Given this list of marker genes DDX18, MYOD1 (NCBI Gene Id 4654), NRIP1, KAT5, KIF18A, MSX2, RAMP3, SSTR1, FAM210B, ESR2, LCOR, GPER1, SFRP1, ZNF703, CFLAR, H2AZ1, NCOA3, HNRNPD, ITGA2, RUVBL2, CCDC62 (coiled-coil domain containing 62), MYOG, PPP1R9B, SRD5A1, HSF1, CRHBP, ABCB1, POU4F1, MMP2, SSTR2, POU4F2 (POU class 4 homeobox 2), AIFM1 (apoptosis inducing factor mitochondria associated 1), EGFR, ESR1, IL10, CCNA2, here is a description of the gene set: Human Gene Set: GOBP_CELLULAR_RESPONSE_TO_ESTRADIOL_STIMULUS studied in species Homo sapiens Any process that results in a change in state or activity of a cell (in terms of movement, secretion, enzyme production, gene expression, etc.) as a result of stimulus by estradiol, a C18 steroid hormone hydroxylated at C3 and C17 that acts as a potent estrogen.